Given this list of marker genes Slc35a4, Dnajc3, Ddx3x, Nck1, Eif4g1, Nck2, Prkch, Eif2ak4, D1Pas1, here is a description of the gene set: species: Mus musculus Any process that activates or increases the frequency, rate or extent of translation as a result of a stimulus indicating the organism is under stress. Mouse Gene Set: GOBP_POSITIVE_REGULATION_OF_TRANSLATION_IN_RESPONSE_TO_STRESS